Given this list of marker genes WASF1, DAPK1, FAM30A, RAG2, APBB2, MGLL, WASHC4, KMT2D, H2AC6, HBP1, RASSF8, N4BP2L2 (NEDD4 binding protein 2 like 2), CYTH1, FBN2, FAM8A1, KDM6B, ROR1, MFAP3, FLI1, CD69, MXI1, MAGI1, ARHGAP32, ZNF211, H3C4, YBX3, MAN1A1, TRIM22, SMAD1, CHST15, IQGAP2, NEK7, OPTN, TRAF6, RIPOR2, ZEB2, IL16, KPNA6, CARD10, H2BC11, SRSF5, PRKCB, RGL2 (NCBI Gene Id 9264), ABI1, SAT1, RFX5, MYO1C, FNBP1L, SCN4A, RHOH, RNASE2, BCL9, SERINC1, SLC16A6, ZSCAN9, CEMIP, KDM4C, CYLD, SECISBP2L, IMPA1, SNX19, NUP214, ZNF862, MTMR1, RGS6, CLK1, SPTBN1, CRYBG3, RNF14, MARF1 (NCBI Gene Id 9665), YPEL1, H1-2, SBSPON, MTMR3, ABCB4, MPPED1, BCL2L1, CEBPD, CD55, ZNF32, BAZ2A, ZNF623, RAPGEF5, ZFP36, GH1, PDIA5, MTSS1, GALNT2, TCL1B, TNFRSF21, SLC24A1, TLE1, CD38, EVI5, CTBS, DNAJB9, CSNK1E, SNAPC3, ENPP4, RNF11, ZKSCAN4, PSEN1, DNMBP, GORASP1, LAMA5, H3C10 (NCBI Gene Id 8357), SPINT2, PTPN12, NPTX1, EIF1, RHOBTB1, SNAP25, SH3GLB1, STX7 (NCBI Gene Id 8417), GUCY2C, SMAD7, ST3GAL5, ZNF548, GADD45G, CXCL2, MPPED2, GPM6A, GAS7, HLA-E, CXCL8, AGFG1, SH2B3 (SH2B adaptor protein 3), TNFRSF17, PTPRE, CXCL3, RPS6KA1, KLF7, RIMS3, RGS16, RNF13, PRB1, RELB, CILK1, ABCG1, DOCK9, ELF2 (E74 like ETS transcription factor 2), MYB, ANKRD17, PIM2, IQCE, RYK, HBS1L, CAND2, BAZ2B, HLX, MLXIP, PPP1R26, CRIM1, SPINK1, PLCB4, VAMP4, P4HA2, CREBBP, GLS, LINC01138, DNASE1L3, TMEM131, RB1CC1, MOB4, OAS2, IL10RB, TTN, SLC25A46, TNFAIP3, MAGI2, H2BC15, MTMR6, ARL3, ADIPOR2, HABP4, CTDP1, SERPINF1, MAGEA11, BRD1, HCK, CTF1, H2BC21, ADAM23, CDKN2D, MIA3, UBL3, PSD4 (NCBI Gene Id 23550), KHNYN, POU4F1, TNFAIP1 (TNF alpha induced protein 1), BTBD3, EPHX2, INSIG2, IRS1, H2BC5, LYST, RPS6KA2, MAU2, HCP5, here is a description of the gene set: studied in species Homo sapiens TCF-1 is an HMG family transcription factor which is known to be critical for T cell development. We discovered that it has a unique role in suppressing malignant transformation of developing thymocytes at early stages. We identified ID2 and LEF-1 as key TCF-1 target genens in tumor suppression. We used microarrays to detect gene expression changes in WT and TCF-1 deficient DN3 thymocytes as well as T cell lymphoma cells developed in TCF-1 KO mice. from publication Yu S, Zhou X, Steinke FC, Liu C, Chen SC, Zagorodna O, Jing X, Yokota Y, Meyerholz DK, Mullighan CG, Knudson CM, Zhao DM, Xue HH (PMID 23103132) Genes up-regulated in DN3 thymocytes: wildtype versus TCF7 knockout. Human Gene Set: GSE33292_WT_VS_TCF1_KO_DN3_THYMOCYTE_UP